Given this list of marker genes TRIB1, EFEMP1, CISH, NMB, GAS6, RHOBTB3, PSAT1, SRSF6, CHI3L1, GOLIM4, PDCD6, FHL1, NFIA, MIDN, RNF13, CTNNB1, FOSB, FOXA3, MIR99AHG, PPDPF, NUDT4, APOD, PPP1R3C, RPS26, SRSF7, POFUT2, TMED4, CFH, WWTR1, ENPP1, GEM, OSMR, NR4A1, ELL2, DNAJB4, BOC, SARAF, MMP3, BAMBI, EGR2, SEC62, CHI3L2, GPC6, P3H2, COL2A1, MFAP4, PRKCZ, TTLL7, FST, BHLHE40, ENHO, THBS1 (thrombospondin 1), AMOTL2, PLA2G2A, ITIH5, TCEAL2, PLXDC2, BCAT1, PHKG1, MT-ND3, TSPAN13, TSPAN6, SMIM14, BTG2, TSC22D1, HRCT1, TSPAN3, RPL35A, IRF1, HSPE1, RARG, NDRG2, CHPT1, SPOCK3, PHGDH, CCNL1, C11orf96, H3-3B, RAB28, CLU (clusterin), NTRK2, NLRP1 (NCBI Gene Id 82286), BEX4, DNAJC19, C5orf15, SUMF2, GADD45B, LEPROT, PCBP2 (NCBI Gene Id 5094), MT-ND5, NDUFC1, PCSK1N, ZFP36, PALS2, IRF2BPL, STK26, TM4SF1, PEBP1, GALNT18, UXS1, SKIL, HSPB6, S100A13, GABARAPL2, RPL24, SLC16A1, CSRNP1, HNRNPA0, SDC2, PDPN, NDN, MDFI (MyoD family inhibitor), HIF1A, COMP, SLC38A3, DOK1, SERPINA1, TIPARP, SELENOW, ZCRB1, RPL3, CHRDL2, KLF10, PPP3CA, MRPL18, PLD3, FAM43A, HES1, GET1, FRZB, FGFBP2, PAM, INSR, LMO4, DDR2, SLC39A14, PID1, MPZL2, PDCD4, NAA38, FBXO2, FXYD6, RPL34, CNPY2, SLC25A36, ZNF385D, RBP4, NOVA1, SLC1A5, RRBP1, CHADL, AK1, COLGALT2, GDF10, SLC14A1, TRPS1, SMARCD3, SEC22B, PAPSS1, CYTL1, ZBTB20, IFT57, here is a description of the gene set: from publication Su Z, Ho JWK, Yau RCH, Lam YL, Shek TWH, Yeung MCF, Chen H, Oreffo ROC, Cheah KSE, Cheung KSC (PMID 38267611) Expressed high levels of genes associated with cartilaginous matrix production; COL21A, COMP, and RARG, suggesting this cluster represents well differentiated neoplastic chondrocytes. The benign sample contained mainly cells from the Chon1 cluster, while low-grade and medium-grade samples contained both Chon2 and Chon1 clusters. Chon1 cells significantly resembled Resting Chondrocytes (RC) from the foetal femur (cosine similarity = 0.66). The Chon1 cluster, enriched in benign tumour and low-grade chondrosarcoma, retained a degree of RC characteristics. The Chon1 signature score was decreased along with tumour grades. Human Gene Set: SU_HO_CONV_CENT_CHONDROSARCOMA_C0_CHON1 The transformation of benign lesions to malignant tumours is a crucial aspect of understanding chondrosarcomas, which are malignant cartilage tumours that could develop from benign chondroid lesions. However, the process of malignant transformation for chondroid lesions remains poorly understood, and no reliable markers are available to aid clinical decision-making. To address this issue, we conducted a study analysing 11 primary cartilage tumours and controls using single-cell RNA sequencing. By creating a single-cell atlas, we were able to identify the role of endoplasmic reticulum (ER) stress in the malignant transformation of conventional central chondrosarcomas (CCCS). Our research revealed that lower levels of ER stress promote chondrosarcoma growth in a patient-derived xenograft mouse model, while intensive ER stress reduces primary chondrosarcoma cell viability. Furthermore, we discovered that the NF-?B pathway alleviates ER stress-induced apoptosis during chondrosarcoma progression. Our single-cell signatures and large public data support the use of key ER stress regulators, such as DNA Damage Inducible Transcript 3 (DDIT3; also known as CHOP), as malignant markers for overall patient survival. Ultimately, our study highlights the significant role that ER stress plays in the malignant transformation of cartilaginous tumours and provides a valuable resource for future diagnostic markers and therapeutic strategies. studied in species Homo sapiens